Given this list of marker genes THAP4, DST, TRNP1, ASB1, PYROXD2, KGD4 (alpha-ketoglutarate dehydrogenase subunit 4), MOB3B, EOGT (NCBI Gene Id 79580), CLK3, ZSWIM6, EPB41L2, HEMGN, NMRK1, SNAI2 (snail family transcriptional repressor 2), JADE2, HNMT, CBR4, BMS1, IFI16, PABPN1, HIBCH, CDK7, COL4A5, PTPRN2, COL7A1, CD81, CFLAR, ABCD4, CASP4, PRDX5, HRAS, ATXN7L1, SRSF8, CFHR1, ARIH1, TTC38 (NCBI Gene Id 55020), HEATR1, BTF3, SALL2, RPS12, RNF44 (NCBI Gene Id 260352), COL4A6, MICAL1, SYTL2, JAG1, PXN, GSDME, ZNF33B, GLI3, ATXN1, ARHGEF40, GRB10 (growth factor receptor bound protein 10), ABCG1, ERAP1, RNF31, SEMA6A, METTL17, ADGRG6, EXTL3, GUK1, MYC, GLUD1, GSTO1, LGMN, RALGAPA1, CNN2, FRMD6, ATF4, SNX19, PI4KB, EPHB6, DAB2IP (NCBI Gene Id 84635), RMND5A, GPSM3, RPS25, MEIS1, RACK1, RND3, DYNC1I2, MED28, GMFG, SPOCK1, SAMD4A, EML2, MLLT10, KRT17, ADRM1, RPS28, SMAD6, POLI, PTPRE, MOB3C, MXRA5, FBLN7, ITGA2, NEIL1, AGFG1, MPZL2, ROS1, MECOM, SH3PXD2A, CPT1B, LPCAT2, NT5E, IGF1R, ZNF516, STX3, CASP1 (NCBI Gene Id 834), CYP24A1, ICAM2, CD44, CHCHD5, NOTCH1, SEPTIN9, CUL4B (NCBI Gene Id 8450), LDOC1, HMG20A, HMBOX1, TBC1D2B, RFX5, NUDT13, SNRPN, PIGB, AARSD1, SLC24A1, LAMB3, OXA1L, TOB2, ITM2C, SEC31B, BMP7, RPL10L, ZNF827, CCND1, LAD1, PDE4D, AJUBA, PTPN13, MYB, PML, FSCN2, MADD, NME4, NLRP1, ZNF655, VWA5A, PRXL2A, PLCG2, LZTS2, KRT14, DYRK4, CTSH, RGS12, FGFR3, OSGEP, BBS1, TMEM120A, ARSD, RPS23, POLR2J2, ZFAS1, TM4SF4, LPAR6, RPL36AL, WDR73, MAST4, SORL1, FABP5, TSPYL1, CDC27, EXT1, RSL24D1, NPAS2, THSD4 (NCBI Gene Id 79875), TK2, TRIP6, DNAAF9, ABCC5, ETFA, FHIP2B, IGBP1, CERT1, DGLUCY, EIF3E, AP1G2, TUSC3, NPM1, RFX2, IKBKB, LINC01138, SEMA4B, ABCC4 (ATP binding cassette subfamily C member 4 (PEL blood group)), PLEKHH3 (pleckstrin homology, MyTH4 and FERM domain containing H3), NRG4, WNT5B, GPX2, TARBP2, ABLIM1, LIMS1, UNC5B, HAPSTR1, PSD3, COL27A1, SNU13 (small nuclear ribonucleoprotein 13), AGR2, DPP8, FAM174B, TRIP12, AHNAK, AKAP13, ARHGAP1, CHD9 (chromodomain helicase DNA binding protein 9), HHAT, DGKA, FGL2, TESC, CDIP1, NDST2, LCAT, MAN2C1, MXD4, SPRY2, DGKH, TMEM216, SMAD3, FARP2, here is a description of the gene set: from publication Lindgren D, Liedberg F, Andersson A, Chebil G, Gudjonsson S, Borg A, Månsson W, Fioretos T, Höglund M (PMID 16532037) Genes whose expression profile is specific to Cluster III of urothelial cell carcinoma (UCC) tumors. We used gene expression profiling, mutation analyses of FGFR3 and TP53, and LOH analyses of chromosome 9 and the TP53 region on chromosome arm 17p, to molecularly characterize 75 Ta and T1 bladder carcinomas. We identified four major cellular processes related to cell cycle, protein synthesis, immune response, and extra cellular components that contribute to the expressional heterogeneity of early-stage urothelial cell carcinoma (UCC). Activating FGFR3 mutations were found at the highest frequency in G1 tumors (80%), and showed a strong correlation with FGFR3 expression. In contrast, G3 tumors displayed mutations in less than 10% of the cases and a low level of FGFR3 expression. Even though LOH on chromosome 9 was not associated with any specific expression pattern, our data indicate that loss of chromosome 9 is associated with tumor development rather than initiation. The combined analyses suggest the existence of two types of UCC tumors, one which is characterized by FGFR3 mutation or expression, high expression of protein synthesis genes, and low expression of cell cycle genes. Furthermore, the presented data underscore FGFR3 receptor involvement in urothelial cell transformation as the presence of FGFR3 mutations has a major impact on the global gene expression profile of bladder carcinomas. Human Gene Set: LINDGREN_BLADDER_CANCER_CLUSTER_3_DN species: Homo sapiens